The following is a description of a gene set: Human Gene Set: REACTOME_ZINC_INFLUX_INTO_CELLS_BY_THE_SLC39_GENE_FAMILY Zinc influx into cells by the SLC39 gene family species: Homo sapiens, and this is the list of marker genes: SLC39A2, SLC39A10, SLC39A4, SLC39A7, SLC39A8 (solute carrier family 39 member 8), SLC39A14, SLC39A5, SLC39A1, SLC39A6, SLC39A3